Given this list of marker genes Ephx2, Aloxe3, Cyp2c50, Cyp2j5, Cyp4a10, Gstp3, Cyp2j11, Cyp4a30b, Elovl5, Cyp4a12a, Fads2, Abcd1, Cyp2c54, Cyp4a32, Cyp2j6, Gstp-ps, Cyp2j12, Alox12, Elovl2, Alox8, Cyp2c55, Cyp2j9 (cytochrome P450, family 2, subfamily j, polypeptide 9), Cyp4a29, Cyp4a14, Cyp2j13, Cyp2j8, Cyp4a31, Alox12b, Abcd2 (ATP-binding cassette, sub-family D member 2), Fads1, Gstm7, Gstp1, Alox15, Acsl1, Cyp2j7, Cyp4a12b, Gstp2 (glutathione S-transferase, pi 2), Pnpla8, here is a description of the gene set: The chemical reactions and pathways involving linoleic acid, an unsaturated omega-6 fatty acid that has the molecular formula C18H32O2. studied in species Mus musculus Mouse Gene Set: GOBP_LINOLEIC_ACID_METABOLIC_PROCESS